The following is a description of a gene set: Human Gene Set: REACTOME_NEGATIVE_REGULATION_OF_NMDA_RECEPTOR_MEDIATED_NEURONAL_TRANSMISSION species: Homo sapiens Negative regulation of NMDA receptor-mediated neuronal transmission, and this is the list of marker genes: LRRC7, PPM1F, NEFL, GRIN2A, DLG4, CAMK4, CAMK2D, CAMK2A, CAMK2G, CAMK2B, GRIN2B, ACTN2, GRIN1, DLG1, DLG3, CAMK1, DLG2, PPM1E, GRIN2D, CALM1, GRIN2C